Given this list of marker genes IL10RB, KRT17, GJB2, GJB6 (NCBI Gene Id 1897), XIAP, IL10RA, IL17RA, MBTPS2, IVNS1ABP, here is a description of the gene set: Folliculitis Human Gene Set: HP_FOLLICULITIS studied in species Homo sapiens Inflammatory cells within the wall and ostia of the hair follicle, creating a follicular-based pustule.